The following is a description of a gene set: Trafficking of AMPA receptors Human Gene Set: REACTOME_TRAFFICKING_OF_AMPA_RECEPTORS species: Homo sapiens, and this is the list of marker genes: CAMK2G, PICK1, GRIA4, GRIP1, AP2S1, GRIP2, CAMK2B (NCBI Gene Id 816), CACNG4, AP2A2, TSPAN7, GRIA1 (glutamate ionotropic receptor AMPA type subunit 1), CACNG8, GRIA2, PRKCB, CACNG2, PRKCA, AP2A1, PRKCG, CACNG3, GRIA3, MYO6 (NCBI Gene Id 4646), CAMK2A, AP2B1, NSF, AKAP5, DLG1, EPB41L1, DLG4, AP2M1, MDM2, CAMK2D